Given this list of marker genes Mad1l1, Ska1, Ska3, Prap1, Mad2l1bp, Aurka (aurora kinase A), here is a description of the gene set: species: Mus musculus Any process that decreases the rate, frequency, or extent of the spindle checkpoint, a cell cycle checkpoint that delays the metaphase/anaphase transition until the spindle is correctly assembled and oriented, and chromosomes are attached to the spindle. Mouse Gene Set: GOBP_NEGATIVE_REGULATION_OF_SPINDLE_CHECKPOINT